The following is a description of a gene set: studied in species Homo sapiens Human Gene Set: GOBP_BASIC_AMINO_ACID_TRANSPORT The directed movement of basic amino acids, amino acids with a pH above 7, into, out of or within a cell, or between cells, by means of some agent such as a transporter or pore., and this is the list of marker genes: SLC7A5, SLC11A1, SLC7A1 (NCBI Gene Id 6541), SLC7A6, SLC25A29, SLC7A3, SLC25A15, SLC38A4, TMEM44, SLC66A1, SLC7A2, SLC38A3, SLC7A9, CLN3, SLC3A2, SLC22A2, SLC47A1, SLC25A2, SLC7A7, SLC7A4, SLC15A4, SLC3A1, SLC38A9